Given this list of marker genes ARID1A, GTF3C3, DNAJB1, GABPB1, GPR180, H2AC5P, SNRPFP2, RPL26L1-AS1, ZFP36, CCDC77, PRPF18, NUF2, RGS5, RPP14, QARS1, VIM, RNVU1-6, ZNF213-AS1, KDM5A, QRICH1, LINC00114, USP35, SHFL, HRAS, RPS26P59, RPL24, ANXA2R-AS1, ENSG00000227496, SLC35A3, PHAX, KCTD9, ENSG00000232995, LNX1, MTF2, ARFGAP3, SDE2, PCBP2, NDUFAF4, GOSR1, TMEM234, ABCD3 (ATP binding cassette subfamily D member 3), STOML1, STX16-NPEPL1, RNU11, KLC2, IER3-AS1, ZNF165, ERRFI1, PDZD9, BRWD1, ZKSCAN8P2 (ZKSCAN8 pseudogene 2), HTD2, LINC01719, NUDT9, CCNJ, NDUFB7, VSTM2L, SNRPB (NCBI Gene Id 6628), H2BC3, CDCA2, BCL6, METTL15, MRPL19, PML, SYT7, GNAS, RPLP1, NME1-NME2, SLC9A1, TGFB1I1, ENTPD1-AS1, FLOT1, RNU6-921P, NUTF2P4, RPL26L1, DHX8, RPL38 (NCBI Gene Id 6169), FAM98B, PTPN2, R3HCC1, BDNF, STX16, EIF2D, TTC5, COL6A1, KCTD21, NME1, DUSP11, GABPB1-AS1, PLXDC1, SYNCRIP, RBM45, ANKRD33B (NCBI Gene Id 651746), here is a description of the gene set: from publication Yevshin I, Sharipov R, Kolmykov S, Kondrakhin Y, Kolpakov F (PMID 30445619) Human Gene Set: UBE2I_TARGET_GENES species: Homo sapiens Genes containing one or more binding sites for (UBE2I) in their promoter regions (TSS -1000,+100 bp) as identified by GTRD version 20.06 ChIP-seq harmonization.